The following is a description of a gene set: The series of molecular signals initiated by a ligand binding to a nucleotide-binding domain, leucine rich repeat containing receptor (NLR), and ending with the regulation of a downstream cellular process. NLRs are cytoplasmic receptors defined by their tripartite domain architecture that contains: a variable C-terminus, a middle nucleotide-binding domain, and a LRR domain that is variable in the repeats composition and number. species: Mus musculus Mouse Gene Set: GOBP_NUCLEOTIDE_BINDING_DOMAIN_LEUCINE_RICH_REPEAT_CONTAINING_RECEPTOR_SIGNALING_PATHWAY, and this is the list of marker genes: Inava, Rnf34, Slc46a2, Nod2, Nagk, Slc15a3, Tnfaip3, Slc15a4, Znrf4, Igtp, Otulin, Hspa1b (heat shock protein 1B, NCBI Gene Id 15511), Rela, Nod1, Erbin, Ptpn22, Slc15a2, Irgm1 (NCBI Gene Id 15944), Tlr4, Nfkbia, Irgm2, Xiap, Ripk2, Lacc1, Peli3